The following is a description of a gene set: Human Gene Set: GSE11961_MARGINAL_ZONE_BCELL_VS_GERMINAL_CENTER_BCELL_DAY40_UP from publication Kaji T, Ishige A, Hikida M, Taka J, Hijikata A, Kubo M, Nagashima T, Takahashi Y, Kurosaki T, Okada M, Ohara O, Rajewsky K, Takemori T (PMID 23027924) Genes up-regulated in marginal zone B cells versus day 40 germinal center B cells. To obtain insight into the genetic basis of the increase of functional activity of memory B cells over time, we compared the gene expression profiles of day 7 and day 40 NP-specific/IgG1 memory B cells, GC B cells and plasma cells in immunized WT mice and naïve B cells, before and after activation in vitro. studied in species Homo sapiens, and this is the list of marker genes: RASL11B, TMPRSS5, TRAPPC6B, MLLT3, ARB2A, NEDD1, SUSD1, SLC35A3, SPACA9, SRCAP, AAK1, IPO8, SLC30A6, ANXA8, MPPED2, PDLIM1, NUP50, PDE3B, TTPAL, SYNE3, SUCO, DDC, ACAA2, ZNF512, KLHL25, ZNF410, SPAG4 (NCBI Gene Id 6676), CTSD, ETFDH, TRAM2, KIAA0753, CD151, FHIT, PPARGC1B, CAPN3, PARD6G, SPTBN1, ETS1, GAB3, MYOT, SLC20A1, C1orf185, MARCHF2, KLRK1, MGA (MAX dimerization protein MGA), PPP1R15B, RBM27, ZPBP2, TIMP2, ALG5, CISH, F2RL1, RNF157, PAFAH1B2 (NCBI Gene Id 5049), ANKRD44, IREB2, HBP1, BORCS7, USP1 (NCBI Gene Id 7398), CHST11, NRIP1, FSTL1, PPFIA1, RCOR1, ATP10A, LCA5, SIPA1, VIRMA, PIGA, CISD3, ALKBH4, FRY, C3orf38, FBXL2, HAUS3, BAIAP3, MEMO1, CHL1, CNIH2, SH3RF1, SENP6, EPHX1, KLHL22, LBR, IKZF1, STRN, NPRL2, FHL2, ARL5B, BCORL1, INPP5B, ZNF280C, HEPH, GAREM1, GLA, N4BP1, CCDC88C, UGCG, GOLGA4, FAM8A1, NCOA6, PPP3CA, TRPC6, AREL1, NASP, NR2C2, CYP17A1 (NCBI Gene Id 1586), RNASE4, ITGB3BP, FLT3LG, ARL5A, SKOR1, FYN, B3GALT5, JAZF1, CDK5RAP2, RTTN, RNASEL, USP38, DNER, SACS, GNPTG (NCBI Gene Id 84572), SEC22C, SCYL1, ANAPC1, ZNF654, KCNAB2, ENPP1, RBM6, CALCRL, MLLT6, PLEKHA8, IPO11 (NCBI Gene Id 51194), SEC24D, NUCB1, RASGRP1, TMCO3, PIM2, PRSS16, KLHL6, DNMT3B, FCGR2A, LONP1, LINC00511, ATP8B2, KCTD10, DIPK2A, RPGR, TSFM, ARID1B, FUT11, RBL1, PRKACB, HDAC3, NIPSNAP3A, KLHDC2, UROD, USP37, STXBP5L, CELA1, CR1L, GABRA6, PADI2, COG6, PIK3R1, CENPQ, GYG1, JAK1, B3GNT5, SENP5, PRKD3, ATP6V0A2, WDR26, TTC28, RHOC, PRDM4, SELENOI, TBL2, CLCN3, AIRN, SMG1, PAM, SPCS2, TRAM1L1 (NCBI Gene Id 133022), PPM1H, PPIP5K1, PRMT9, TBC1D20, CDKN2D, NLRC5, CHRM3, IL27RA, RIMOC1, ANGPTL4, PDZD8, CD38, PPP1R36, TOP1MT, CRACDL, DHX15